Given this list of marker genes Nlrp4e, Sqstm1, Mettl3, Eif4e2, Thy1, Tsc22d1, Flt3, Syt11 (synaptotagmin XI), Pla2g5, Pla2g2d, Stat6, Nlrc5, Qki, Cnot7, Hspa9, Scgb1a1, Ptger4 (NCBI Gene Id 19219), Cd46, Clnk, Bpifb1, Tff2, Btla, H2-M3, Btk, Ccl21d, Runx1, Mmp12, Aurkb, Cd276, Gfer, Lrfn5, Lrrc14, Serpinb9e, Smpdl3a (NCBI Gene Id 70336), Lilrb4b (NCBI Gene Id 14727), Oas1a, Gata2, Lgr4, Ufl1, Il4i1, Dtx1, Tmem178, Pias3, Nfkbid, Dgkz, Ccl21e, Nck1, Znrf4, Il12b, Gpnmb, Pglyrp3, Stat2, Axl, Muc4, Casp3, Mul1 (NCBI Gene Id 68350), Tnfrsf13b, Fer, Marchf7, Il2ra, Csnk1a1, Nckap1l, Vsig4, Tob2, Oas3, Prg2, Shh, Ccr2, Zfp35, Rc3h1, Thbs1, Oas1g, Parp3, Nfkbil1, Grem1, Gigyf2, Serping1, Atg5, Nlrp4c, Zc3h8, Bst2, Pag1, Prdm16, Wdr41, Cdk6, Myc, Ccl3, Hmgb3, Gpatch3, Aars2, Hlx, Zc3h12a, Trim32, Nlrx1, Trem2, Cbfb, Cd160, Ifi208, Dusp1 (dual specificity phosphatase 1), C1qbp, Mif, Nlrp4f, Sh2d1b2, Socs1, Rnf170, Spsb3, Prnp, Snai2, Ptpn2, C5ar2, Ptpn11, Trafd1, Il33, Oas1e, Oas1h (2'-5' oligoadenylate synthetase 1H), Slc4a2, Zdhhc12, Ptprs, Fbxo7, Sfrp1, Cst7, Tap2, F2rl1, Trim31, Ndfip1, Ctla4 (NCBI Gene Id 12477), Id2, Ctsg, Atg12, Cd274, Ins2, Dpp4, Ifnb1, Igf1, Rara, Ins1, Il10, Plcb1, Ildr2, Nme2, Btnl2, Nod2, Nectin2, Cyp19a1, Ttll12, Lyar, Cd68, Lag3, Pla2g2f, Il7r, Arg1, Ogt, Tgfb3, Nme1, Adcyap1, Lgals1, Cd84, Fbxl2, Smad7 (SMAD family member 7), Mia3, Jak3 (NCBI Gene Id 16453), Fcgr2b, Gper1, Cr2, Hmox1, Ythdf2, Zc3h12d, Prdx2, Usp15, Spn, Cblb, Tnf, Rhbdd3, Psmb4, Cactin, Cartpt, Pira12, Foxf1, Runx3, Gal, Cebpa, Cebpb, Adgrf5, Rag2, Pten, Wasl, Dlg1, Nbl1, Cd200r1, Mndal, Tapbpl, Tgfb1, Mmp28, Irf4, Clec12a (NCBI Gene Id 232413), Riok3, Inpp5d, Tap1, Dcst1, Zp3r, Gpr17, Gpr55, Ubash3b, Il3, Fcer1g, Lrrc17, Il13ra2, Dtx4, Hspa8, Nectin4, Laptm5, Erbin, Pkn1, Tigit, Ptpn6, Fstl3, Sftpd, Lyn, Ccl12, Enpp3, Tmem176b, Cd300a, Sfn, Gcsam, Masp1, Cldn18, Gpr108, Cuedc2, Nmi, Mafb, Ifi206, Ccl28, Zpbp2, Serpinb9g, Tspan32, Cd55b, Ifi203, Rc3h2, Sox11, Rnf115, Oas1b (2'-5' oligoadenylate synthetase 1B), Clec2d, Fcrl5, Tcta, Slamf1, Emilin1, Oas1d, Hc, Foxj1, Ccl21b, Ceacam1, Pde5a, Samsn1, Tbx21, Cnn2, Prkar1a, Akt1, Mfhas1, Ccl21a, Selenos, Cd55, Rab7b, Dusp3, Ptpn22, Tnfrsf21 (tumor necrosis factor receptor superfamily, member 21), Susd4, Dhx58, Serpinb9, Tmem176a, Ifi203-ps, Lrrc32 (leucine rich repeat containing 32), Gpr137, Slit2, Il1rl1, C9orf72, Mavs, Trim27, Ccr1, Trim21, Mkrn2, Gpr18, Cd300lf, Angpt1, Ccl21f, Npy5r, Slfn1 (schlafen 1), Drd2, Nlrc3, Gpr68, Erbb2, Arg2, Tsc2, Ufd1, Usp38, Il27ra, Src, Mad1l1, Lax1, Pglyrp1, Socs6, Gpam, Ltf (lactotransferrin), Havcr2, Lgals3, Cdkn2a, Irak3, Rabgef1, Ifi213, Tnfrsf11b (NCBI Gene Id 18383), H2-T23, Xcl1, C4bp, Lyplal1, Dlg5, Stat5a, Spi1, Clec4g, Klrk1, Cul4a, Adora2a, Trim30a, Bpi, Lpxn, Irgm1, Fgl2, Epx, Arrb2, Tspan6, Anxa1 (annexin A1), Sox9, Elf1, Il4ra, Sdc4, Ptprc, Mefv, Gdf15, Tnfrsf14, Mdk, Pibf1, Pf4, Klrd1, Mertk, Cr1l, Parp1, Oas1f, Siglecg, Bmyc, Itch, Tax1bp1, Klrb1b, Pglyrp2, Fbn1, Twist2, Pik3ap1, Ifng, Pla2g2a, Zbtb7b, Ywhae, Col3a1, Serpinb9h, Bcr, Sec14l1, Nlrp6, Sarm1, Nlrp4b (NLR family, pyrin domain containing 4B), Lilrb4a, Clec2g, Fam3a, Pdcd1lg2, Ctnnb1, Vsir, Dnaja3, Ezr, Ascl2, Pparg, Gps2, Serpinb9d, Sh2d1a (NCBI Gene Id 279676), Pilrb1, Hfe, Tlr6, Cd44, Dusp10 (NCBI Gene Id 98270), Ada, Ptgs2os, Plcl2, Cd59a, Hoxa7, Apoa2, Ahr, Sirt2, Cnr1, Tarm1, Cd200, Nrarp, Adtrp, Dapl1, Btn2a2, Pim1, Zfpm1, Ihh, Cd22, Parp14, Il17d, Itpripl1, Tkfc, Igtp, Tyrobp, Usp18, Bank1, Pdcd1, Tnfaip3, Cd96, Ifi209, Hmgb1, Tnfsf18, Cep63, Olfm4, Lst1, Gimap5, Nf1, Glmn, Npy, Gli3, Cx3cr1, Cd37, Clec2i, Milr1, Sh2d1b1, Otop1, Apoa1, Tnfaip6, Zdhhc18, Apcs, Gpx2 (glutathione peroxidase 2), Phpt1, Trib1, Atg9a, Ppp6c, Rassf5, Cd69, Sla2, Trim11, Ythdf3, Serpinb9b, Isg15 (NCBI Gene Id 53606), Lgals9, Pdpk1, Scrib (NCBI Gene Id 54559), Abhd17a, Abr, Vpreb3, Psma1, Bmp4, Ticam2, Cx3cl1 (NCBI Gene Id 58173), Fn1, BC037156, Iapp, Adipoq, Erfe, Klre1, Ldlr, Bcl6, Inpp4b, Slamf8, Samhd1, Ppt1, Kitl, Ppp3cb, Pcbp2, Serpinb9f, Adar, Cd80, Acod1, Il2, Pglyrp4, H2-Ob, A2m, Cptp, H2-Aa, Fbxw7, Clec12b, Banf1 (NCBI Gene Id 98145), Adora1, H2-Oa, Atm, Loxl3, Fgl1, Dusp22, Nploc4, Thoc5, Ypel4, Tbc1d10c, Tnfaip8l2, Appl1, Igf2, Dab2ip, Grb2, Pik3r1, Ccl25, Ubash3a, Hspb1, Socs5, Peli1, Acp5, Fas, Gimap3, Tyro3, Otud4, Rps19, Fcrlb, Gnrh1, Irgm2, Twsg1, Tafa3, Trex1, Tsc22d3, Rnf125, Lamp2, Il20rb, Gpr137b, Padi2, Crtam, Lrch1, Ifi214, Ddx39a, Ywhaz, Apod, Dll1, Ccn3, Gpx1, Twist1, Nr1d1, Vtcn1, Fadd, Grn, Oas1c, Ptprj, Cgas, Il4, Tjp2, Cnr2, Cd74, Ido1, Btrc, Nr1h3, Prkdc, Foxp3, Pawr, Serpinb9c, C1qc, Crk, Fam76b, Fgr, Ifi207, Ripor2, Pira1, Pvrig, Tarbp2, Alox15, Tnfsf4, Cd86, Zfp608, Smcr8, Tgfb2 (NCBI Gene Id 98738), Stap1, Cd24a, Cxcl12, Tmem131l, Cd59b, Smpdl3b, Tnfrsf4, Tmbim6, Nlrp4a, Rin3, Irf1, Mill1, Ubqln1, Zbtb46, Gramd4, Smim30, here is a description of the gene set: Mouse Gene Set: GOBP_NEGATIVE_REGULATION_OF_IMMUNE_SYSTEM_PROCESS Any process that stops, prevents, or reduces the frequency, rate, or extent of an immune system process. studied in species Mus musculus